The following is a description of a gene set: Regulation of PLK1 Activity at G2/M Transition species: Mus musculus Mouse Gene Set: REACTOME_REGULATION_OF_PLK1_ACTIVITY_AT_G2_M_TRANSITION, and this is the list of marker genes: Haus4, Pafah1b1, Rps27a, Tuba4a, Ccnb2, Cdk5rap2, Uba52rt, Cdk1 (cyclin dependent kinase 1), Cep72, Tuba1a (tubulin, alpha 1A), Plk1 (NCBI Gene Id 18817), Dync1h1, Ckap5, Cep131, Cul1, Dync1i2, Prkaca, Nek2, Haus2, Cep41, Csnk1d, Cep135, Csnk1e, Cetn2, Dynll1, Nedd1, Cep43, Mapre1, Tubg1, Bora (NCBI Gene Id 77744), Ajuba, Haus3, Haus6, Odf2, Cenpj, Tubb5, Cep70, Ppp1r12a, Plk4, Haus7, Cep57, Uba52, Ccnb1, Hsp90aa1, Ccp110, Cep76, Nde1, Ninl, Skp1, Ubb, Cep290, Dctn3, Optn, Alms1, Actr1a, Ppp1r12b, Tubb4b, Cep164, Sdccag8, Cep250, Haus8, Rab8a, Fbxw11, Ppp2r1a, Ppp1cb, Ubc, Cep78, Dctn1, Cep63, Haus5, Ssna1, Ofd1, Aurka, Cep152, Haus1 (NCBI Gene Id 225745), Cep192, Ywhag, Pcm1, Sfi1, Dctn2, Ywhae, Tubb4a, Clasp1, Akap9